Given this list of marker genes TRAF6, CHUK, UBB, UBE2N, IKBKB, UBC, PELI3, IKBKG, PELI2, IRAK1 (interleukin 1 receptor associated kinase 1), RPS27A, PELI1, UBE2V1, UBA52, here is a description of the gene set: part of: TRAF6 mediated induction of NFkB and MAP kinases upon TLR7/8 or 9 activation Reactome Pathway: IRAK1 recruits IKK complex upon TLR7/8 or 9 stimulation The role of IRAK1 kinase activity in the activation of NF-kappa-B by IL-1/TLR is still uncertain. It has been shown that a kinase-dead IRAK1 mutants can still activate NF-kappa-B. Furthermore, stimulation of IRAK1-deficient I1A 293 cells with LMP1 (latent membrane protein 1- a known viral activator of NF-kappa-B) leads to TRAF6 polyubiquitination and IKKbeta activation. On the other hand, IRAK1 enhances p65 Ser536 phosphorylation and p65 binding to the promoter of NF-kappa-B dependent target genes.<p> IRAK1 has also been shown to be itself Lys63-polyubiquitinated (probably by Pellino proteins, which have E3 ligase activity). Mutation of the ubiquitination sites on IRAK1 prevented interaction with the NEMO subunit of IKK complex and subsequent IL-1/TLR-induced NF-kappa-B activation. These data suggest that kinase activity of IRAK1 is not essential for its ability to activate NF-kappa-B, while its Lys63-polyubuquitination allows IRAK1 to bind NEMO thus facilitating association of TRAF6 and TAK1 complex with IKK complex followed by induction of NF-kappa-B. </p><p>Upon IL-1/TLR stimulation IRAK1 protein can undergo covalent modifications including phosphorylation, ubiquitination and sumoylation. Depending upon the nature of its modification, IRAK1 may perform distinct functions including activation of IRF5/7, NF-kappa-B, and Stat1/3. species: Homo sapiens